Given this list of marker genes GNS, BCS1L, AFF4, SMARCAL1, VPS33A, SPRED2, TP63, NAGLU, LPAR6, SOS2, HEATR3, ATP7A (ATPase copper transporting alpha), CCDC47, SUMF1, RAF1, NOTCH2, CERT1, SEC23A, FLNA, TMCO1, ATP6V0A2, NECTIN4, TGM3, CBL, PLOD3, PTPN11, NOTCH3, IKBKG, LZTR1, NRAS, C18orf32, SGSH, ERCC3, EPS8L3, ATP6V1E1, GUSB, RPS6KA3, RIT1, PADI3, SLC25A24, EBP, RRAS2, PPP1R13L (protein phosphatase 1 regulatory subunit 13 like), GON7, HR, KRAS, ATP6V1A, RASA2, OFD1, PTEN, HGSNAT, KRT74 (keratin 74), MRAS, BCKDK, RRAS, PPP1CB, SREBF1, SOS1, here is a description of the gene set: Hair shafts are rough in texture. Coarse hair studied in species Homo sapiens Human Gene Set: HP_COARSE_HAIR